Given this list of marker genes FSHB, GNRH1, TRANK1, CDH23, GNRHR, GPR101, HFE, AIP, USP8, DUSP6, SLC2A3, FGF8, GNAS, CDKN2C (cyclin dependent kinase inhibitor 2C), TP53, HTT, KISS1R, NR3C1, FGF17, KISS1, ARMC5, BMP6, CDKN1B, CDKN1A, KDM1A, ATRX, CHD7, PROKR2, MEN1, HS6ST1, TAC3, FGFR1, SPRY4, NHLH2, WDR11, TACR3, ABCD1, NSMF, NR0B1, CDKN2B, PROK2, BRAF, USP48, here is a description of the gene set: Abnormal libido species: Homo sapiens Any deviation from the normal sexual drive or desire for sexual activity. Human Gene Set: HP_ABNORMAL_LIBIDO